The following is a description of a gene set: Abnormality of the calcaneus Human Gene Set: HP_ABNORMALITY_OF_THE_CALCANEUS An abnormality of the calcaneus, also known as the heel bone, one of the or heel bone, one of the components of the tarsus of the foot which make up the heel. studied in species Homo sapiens, and this is the list of marker genes: LBR, GJB2, ZEB2, ITPR1, RAB33B, EZH2, SATB2, ATP6AP2, PHGDH, FLNA, SYT1, ADAMTSL1, CCDC8, FLNB, HOXD10, ECEL1, MET, COL1A2, NALCN, RSPRY1, TPM2, HADHA, HADHB, AEBP1, COL2A1 (NCBI Gene Id 444981), FBN1 (fibrillin 1), HDAC6, TNNI2, OBSL1, GJB6, GFM2, DLK1, KANSL1, DYM, MEG3, RTL1